The following is a description of a gene set: Combining with a protein hormone to initiate a change in cell activity. Human Gene Set: GOMF_PROTEIN_HORMONE_RECEPTOR_ACTIVITY studied in species Homo sapiens, and this is the list of marker genes: PAX8 (paired box 8), AMHR2, GNRHR2, EXTL3, LGR5, CMKLR2, LGR6, LHCGR, IGF1R, INSRR, MCHR1, LGR4, RXFP2, INSR, FSHR (follicle stimulating hormone receptor), TSHR, GPR173, CMKLR1 (NCBI Gene Id 1240), ADIPOR2, ADIPOR1, GNRHR